Given this list of marker genes Optn, Psenen, Prex1, Gna13, Nfkb1, Bag4, Fadd, Arhgef1, Rtn4, Omg, Mib2, Myd88, Ngfr, Sppl2b, Ywhae, Vav1, Tnfaip3, Bad, Ikbkb, Fasl, Arhgef10l, Fgd1, Tradd, Arhgef3, Arhgef7 (Rho guanine nucleotide exchange factor), Sqstm1, Rela, Rps27a, Arhgef10, Usp21, Tab2, Rack1 (NCBI Gene Id 14694), Sos2, Arhgef39, Arhgef17, Tnfrsf1a, Smpd2, Itgb3bp, Fgd2, Irak1, Ngef, Ube2d1, Casp8, Cyld, Mag (NCBI Gene Id 17136), Arhgef12, Otud1, Ngf, Casp3, Nfkbia, Arhgef37, Lingo1, Mapk8, Traf1, Psen1, Usp4, Casp2, Ulk1, Clip3, Birc3, Sppl2a, Arhgef33, Tab3, Itsn1, Tab1, Spata2, Arhgef38, Arhgef15, Tnf, Fas, Ubb, here is a description of the gene set: part of: Signal Transduction Reactome Pathway: Death Receptor Signaling studied in species Mus musculus electronically inferred by orthology from the curated human pathway This event has been computationally inferred from an event that has been demonstrated in another species.<p>The inference is based on the homology mapping from PANTHER. Briefly, reactions for which all involved PhysicalEntities (in input, output and catalyst) have a mapped orthologue/paralogue (for complexes at least 75% of components must have a mapping) are inferred to the other species.